The following is a description of a gene set: species: Homo sapiens Human Gene Set: GSE19374_UNINF_VS_LISTERIA_INFECTED_MACROPHAGE_DN Genes down-regulated in bone marrow-derived macrophages: control versus Listeria infected. Macrophages phagocytose bacteria. Certain pathogenic bacteria access and replicate within the cytosol of infected macrophages and induce changes in macrophage gene expression by triggering of innate immune receptors and/or the effects of bacterial virulence factors. We used microarray analysis to identify changes in macrophage gene expression following infection with Listeria monocytogenes. from publication Rayamajhi M, Humann J, Penheiter K, Andreasen K, Lenz LL (PMID 20123961), and this is the list of marker genes: STYK1, PHF20, WFDC8, SLC5A1, RARA, TRIL, TMOD3, ADAP2, S100A7, ARHGEF5, BIK, CHAT, DENND4A, UGGT2, NPY2R, NCOA6, PPP2R5B, TAB2, LRCH1, SH3TC2, SPAG4 (sperm associated antigen 4), ATG9A, FNDC3B, BCKDK, NAMPT, NEK4, ZC3H12A, EHBP1L1, SZT2, CDK9, AGO2, SERPINB4, SIN3B, MS4A3, TRMU, QPCT, LINC01587, HDGF, CSH1, DNTT, TRIB1, CEP76, DNAH17, PROM1, KIF13B, RPS6KB1, SMG6, CLDN7, ABCB1, KANK3, GPER1 (G protein-coupled estrogen receptor 1), CRTAM, C21orf91, ZSWIM8, SEPTIN7P11, PLA2G2F, CXCR4, PIGO, TMEM259, ZNF266, SLC16A3, ERCC3 (NCBI Gene Id 2071), OVOL2, MGAT4A, ZNF211, MON1B, RNF39, TAS2R9, DENND5A, TOM1, AFAP1, TRRAP, CYP3A43, PDE8A (phosphodiesterase 8A), SPRR2B, CCR6, CMPK1, MAFF, SOX15, RNF208, PTBP1, RFC1, GPN2, CEACAM5 (CEA cell adhesion molecule 5), SPTLC2, SAP130, RARS2, IRGC, KCNF1, RFNG, TPCN1, PPIP5K2, NLGN1, DAP, KPNA4, LIPE, SH3BP4, GABRA6, DAPK3, LRIT1, SNCB, HCRTR2, KRT12, SNRPA, FAM53C, AP2A2, GARRE1 (NCBI Gene Id 9710), TESK1, DNAJC1, AGFG2, STK10, PNLIPRP2, ZPBP, SLC9A1, WBP11, RNF187, RALBP1, PTP4A2, TIGD6, ERO1A, CCN3, CTC1, CATSPERB, FERMT2, CFHR4, SNX16 (NCBI Gene Id 64089), VRK2, CGGBP1, PRSS22, MYH4, HERC2P3, RBPMS, PLOD1, RAB5B, PTPRH, NR2C1, SERTAD3, ACVR2A, GK3, KLF4, PTK2B, BRD1, DOP1A, DEFB4A, TARS1, PPFIA1, ATP6V0C, GK (NCBI Gene Id 2710), CASP10, GNE, PEX14, GYS1 (glycogen synthase 1), SAMSN1, PIAS1, PALB2, DOCK4, RB1, GLRX, NOC4L, PPM1A, MED24, PIAS3, ABHD5, DSN1, ASIP, INSR, TAF13, EXOC2, MEN1, PPM1B, CA12, EMC3, ABCD4, CBLL1, ARHGAP26, WDR26, TMEM51, RHCG, SHANK1, CRYM, LGALS2, GTPBP2, DUOX2, RUSF1, ATP1B4, CSNK2A2, COG5, LNPEP, PARM1, HRH2, RBM47, LRRTM2, ARL1, GOLT1B, IL36G, CRAT, BRD8, PRKACA (NCBI Gene Id 5566)